Given this list of marker genes NGFR, ZNF705EP, PRMT8, HOXA5, CDH11, ALDH5A1, SLC7A2, ADORA2B, PKIA, GOLGA1, MYH10, ELFN2, FRS3, MED12L, HAPLN1, FAM217B, ITGA8, ABL2, RBPMS2, PRR3, ERICH3, HSDL1, RNF139, CCNK (cyclin K), TMA7, NEURL4, PCLO, EDAR, MED14, ABCA1, KLHL31, AQP11, MAP3K4 (mitogen-activated protein kinase kinase kinase 4), NR2F6, FLRT3, SLCO5A1, ONECUT2, ATP1A2, CCNY, WDR37, SMAD4, TMEM91, PAX9, HOXA10, FGF7, WDCP, DNAJC27, HDHD2, PTGER3, USP42, ST14, MAP2K7, CACNA2D3, SEC62, TAF5L, SLC35A3, NXF1, AK4, KMT5B, COG7, ABHD6, CCNJ, CLSTN2, VSIG10, NR1D2, PLK2, ID4, TMEM170A, EN2, TRIL, ADAMTSL1, ERG, SYNRG, KCNJ3, BICC1, GPAM, ATP11C, GALNT3, ZMAT3, SPTLC2, KMT5A, AMPD3, NECAP1 (NCBI Gene Id 25977), WBP1L, SMOC2, CAND1, APPBP2, PLCH1, TMEM9B, ST3GAL6, PRKCB, UNC13C, MKNK2, GATC, TMBIM6, PNPLA7, ZBTB39, POU3F2, CEP135, RUNX1, RCAN2, DDX5, PLXND1, DYNLL2, COLEC10, DNAAF9, GALNT7 (NCBI Gene Id 51809), LPIN1, PAIP2, GRIN2D, CCNG1, GAREM1, STAG1, KLF3, BNIP3, TOM1L1, FBLN5, ITGA5, PEDS1-UBE2V1, RIPOR2, ANKS1A, UBE2N, EHF, BEND4, HSD17B12, UNC5D, EFNB2, CNN3, INSM2 (INSM transcriptional repressor 2), CECR2, RREB1, SGIP1, UBE2V1, BTG1, ZNF608, CREBRF, DCAF7, YWHAQ, NDUFC2-KCTD14, MAP2K4, ADGRA3, TMCC1, SLC5A7, TSPYL1, ZCCHC24, RNGTT, NEURL1B, NRK, ZIC5, PSMA1, FBXW7, FBXO45, RAB11FIP1, RARA, TRAF3, NR3C1, THRB, TMEM184A, POU2F3, FAM76B, EPS8, USP25, PATZ1, ZHX1, INA, PF4, TNRC6B, FOXO3, SATB2, STX16, EEF1AKMT4-ECE2, WSB1, NPEPPS, ALG9, BEX3, ADAMTS10, GLRA2, SS18L1, FOSB, KPNA3, LIMK1, INPP1, ZNF800, EGFR, SSH1, FOXP4, RCOR3, MMD, RGPD5, PSPC1, KCMF1, GSPT1, CSRP2, SH3GL3, KPNB1, CACNG2, TET1, GLTP, GAB1, FZD4, TRIM50, ZFHX3, ARF3, OTX2, EDEM3, TERB2, CCNC, BLTP1, PPIF, HIP1, ACVR1C, ARX, CBLB, MTURN, TRPV3, GPR6, KCTD8, SZRD1, TSC22D2, BRPF3, MKLN1, MAGI3, SIK1, PRKX (NCBI Gene Id 5613), RALGAPA2, KCNA4, SNAP25, GATA3, APOOL, LYSMD3, PDE10A, ARL4C, SLC9B1, BNIP2, CPPED1, RCBTB1, PF4V1, CCM2, NR2C2, ZBTB34, PEG10, SLC9A4, NCOA5, TSC1, ARRDC4, LPAR6, GATAD2A, EPB41, HOXC6, TICRR, C2CD2, ZMYM4, KITLG (NCBI Gene Id 780897), NOVA1, FBXO34, SLC24A4, TEAD1, QKI, TRAPPC8, SLC6A1, MOCS3, CTH, NKAIN1, PAIP2B, KCNN3, HBEGF, GRM5, ARHGEF26, CA10, FCRL1, LIFR, COPZ1, ENDOU, LIPT2, PARD6B, PALM2AKAP2, WNK3, ATP2B1, PPP1CC, SEMA6A, KDM7A, AFAP1, CDS1, MDN1, B4GALT3, SLC24A1, GEM, SHE, SOWAHA, EDRF1, GOLM1, HSPD1, RGPD6 (NCBI Gene Id 729540), SEMA7A, SUCO (NCBI Gene Id 51430), NR5A2, SERBP1, SCAF11, SBF2, PDK4, NRBF2, PLPPR1 (NCBI Gene Id 54886), NF1, DEPDC4, RPGRIP1L, RUFY3, NREP, PTCH1, RASSF3, UGCG, DYRK1A, C1orf52, NEMP2, VAPB, RMND5A, TNRC18, DLL4, TAPT1, TCIM, NIPAL4, SEMA6D, LARP4, NRP2, INPP5J, ADAMTSL3, RPS6KA5, USP46, ZFP36, SLITRK1, PLEKHA5, TRERF1, CREB1, NPAS3, PELI2, UNKL, KAT2B, FCRL2, TLK2, PDHX, PRLR, GATA2, GRB2, BTG2, CELF2, TNPO1, SNRNP27, RNF38, MTMR4, GRAMD1B, IRF4, BMP3 (NCBI Gene Id 651), SOX7, ZSCAN26, CTU1, CCNT2, ARFGEF1, BRWD3, ZNF84, FUBP3, FRMD6, RC3H1, KHSRP, LONRF1, ZNF426, CHL1, RGS8, SLC39A11, COMMD3-BMI1, RYBP, RELN (NCBI Gene Id 5649), ABHD17C, ABCB9, NSD1, AHSA2P, RPN2, PIK3CA, PANK1, NAV2, CDIP1, SIX1, IKZF2, SLFN5, RGPD8, PLEKHJ1, ROR1, SFRP1, TMPRSS7, NCALD (NCBI Gene Id 93992, neurocalcin delta), ADCY6, B3GNT7, BEST1, OAF, NECAB1, PRKG1, PLAG1, KCNK2, ARHGAP32, AFF4 (ALF transcription elongation factor 4), GRIA3, LPCAT1, GPT2, PDE7B, NDUFS4, ZFAND3, PNISR, COLGALT2, AKIRIN2, NPTN, NABP1, SFSWAP, RSBN1L, TRIM23, PLPP3, OGA, CHKA, TPR, REPS1, SORL1, EYA4, CRACDL, COL19A1, RAPH1, CAMTA1, GRIA4, ZNF708, NEDD4, KMT2C, HYOU1, CAMK1D, CKAP4, PHLPP2, SLC35F4, ECE2, ARMC8, PLCL2, EIF5A2, PDIA5, NR2F2, TOR2A, SEH1L, ASAH1, SOS1, SOX11, SCAI, DCAF12, SRGAP2, DOT1L, CALD1, CSF1, E2F7, LCOR, MTARC1, PSEN1 (presenilin 1), GPD2, TTC39A (NCBI Gene Id 22996), ITSN2, SPATA13, CMKLR1, PCDH9, KLHL29, RGPD4, MYT1, FBXO10, RSPO3, CDC42EP3, PCNX1, ATAD2B, MRPS14, PAQR9 (progestin and adipoQ receptor family member 9), SNN, KCTD14, FOXO1, SETD5, RO60, STAC, NXT2, CCDC28B, OTULIN, GATA6, PDPK1, ENSG00000275993, SYNJ1, MSL1, HIC1, GCC2, CDK18, DCP1A, NEK6, ST6GALNAC3, BLTP3A, SLC25A25, C11orf58 (NCBI Gene Id 10944), RGL2, NHLH2, CEMIP, DIPK1A, SLC25A16 (solute carrier family 25 member 16, NCBI Gene Id 8034), NCOA7, CHD7 (chromodomain helicase DNA binding protein 7), MAPK14, SPRY2, CCN4 (cellular communication network factor 4), MATN3, KDM3A, FOXA3, TBR1, ZNF268, FAM133B, HS2ST1, MARK1, MS4A7, MDM4, HIPK2, CDR2, XPO1, POGLUT1, USP31, MIGA2, HIVEP3, INO80D, KBTBD8, SLC7A11, AGFG1, SMAD5, HSPH1, AMD1, DCUN1D4, ABITRAM, SHC4, RPS6KB1, ELAVL2, PNKD, DKK2, SCN1A, NETO1, TFAP2B, LOX, NCAM1, EPB41L4A, MAP1B, ANK1, AKIRIN1, MIER2, PPARG (NCBI Gene Id 5468), SLIT2, PDE3B, PHB1 (NCBI Gene Id 5245), FN1, AGRN, VAV3, STK39, STMN2, LITAF, DTNA (NCBI Gene Id 86552), MBTD1 (mbt domain containing 1), TRAF3IP3, NUP210, PEAK1, SLC22A23, RNF8, GFPT2, PPP4R2, RAP2A, PDS5B, SRL, DNAJC13, CLK2, MGAT4A, STYK1, EYA1, CAPN15, GXYLT1, VAV2, MIER3, SMAD9, SLC9A7, NRARP, UBR5, WIPF2, SLC30A7, DYNC2LI1, ARHGEF7, MTCL2, CDH5, IPMK, PTGDR, KIAA0319L, CLCN3, ZBTB20, ZDHHC17, SNX10, YWHAB, STAB2, HYCC1, TAB3, CYP39A1, ASPH, HMGCR (NCBI Gene Id 3156), KCNK5, ACTA2, ZNF80, FAM184A, INSR, ZNF329, SRP19, USF3 (upstream transcription factor family member 3), SLC35F1, COL21A1, SLC13A3, TXLNG, TGFBR3, ABHD17B, PLEKHH1, ING5, TMEM170B, RNF141, GNS (glucosamine (N-acetyl)-6-sulfatase), GNG12, FAM171A1, RAPGEF2, HEG1, FAM78A, CIPC, here is a description of the gene set: Genes predicted to be targets of miRBase v22 microRNA hsa-miR-27a-3p, hsa-miR-27b-3p in miRDB v6.0 with MirTarget v4 prediction scores > 80 (high confidence targets). Human Gene Set: MIR27A_3P_MIR27B_3P from publication Chen Y, Wang X (PMID 31504780) studied in species Homo sapiens